The following is a description of a gene set: studied in species Homo sapiens Any process that modulates the frequency, rate or extent of the directed movement of a motile cell or organism towards a higher concentration in a concentration gradient of a specific chemical. Human Gene Set: GOBP_REGULATION_OF_POSITIVE_CHEMOTAXIS, and this is the list of marker genes: F2RL1, VEGFB, AZU1, SMAD3, ITGA2, F7, ARTN, KDR, NTF3, VEGFC, CDH13, PGF, CXCL12, ANGPT2, NTRK3, CASR, AGER, F3, FGF10, S1PR1, SCG2, IL16, CXCL8, CREB3, VEGFD, VEGFA